The following is a description of a gene set: Reactome Pathway: Matriglycan biosynthesis on DAG1 studied in species Mus musculus This event has been computationally inferred from an event that has been demonstrated in another species.<p>The inference is based on the homology mapping from PANTHER. Briefly, reactions for which all involved PhysicalEntities (in input, output and catalyst) have a mapped orthologue/paralogue (for complexes at least 75% of components must have a mapping) are inferred to the other species. electronically inferred by orthology from the curated human pathway part of: DAG1 glycosylations, and this is the list of marker genes: Crppa, Fktn, Fkrp, Slc35a4, Dag1